Given this list of marker genes RAB11FIP5, ABCC8, UCN, OSM, SYTL4, INHBA, PTPN11, NPFF, PSMD9, GNAZ, MTNR1B, EDN1, RAB11FIP1, LIF, CRY1, CRHBP, GHRL, CCN3, RAB11FIP3, TSPO, ADIPOQ, GNAI1 (NCBI Gene Id 2770), KCNJ11, KCNK9, NMB, CHGA (chromogranin A), IRS1 (NCBI Gene Id 3667), GNAO1, SIRT4, SREBF1, NDUFAF2, VSNL1, PDE8B, NPVF, F2RL1, FAM3D, HADH, PFKL, GHSR, FFAR2, CRY2, DRD2, ADRA2C, JAGN1, CRH, FFAR4, KCNB1, ADRA2A, MIDN, FGF23, TACR2, ACVR1C, PRKN, ENY2, PIM3 (NCBI Gene Id 415116), ADORA1, INHBB, GJA1, BMP8A, LEP, FOXO1, FKBP1B, IL1B, IL11 (NCBI Gene Id 3589), REST, CARTPT, KLF7, INHA, UCP2, OPRK1, here is a description of the gene set: species: Homo sapiens Human Gene Set: GOBP_NEGATIVE_REGULATION_OF_HORMONE_SECRETION Any process that stops, prevents, or reduces the frequency, rate or extent of the regulated release of a hormone from a cell.